The following is a description of a gene set: species: Homo sapiens Human Gene Set: TNCATNTCCYR_UNKNOWN from publication Xie X, Lu J, Kulbokas EJ, Golub TR, Mootha V, Lindblad-Toh K, Lander ES, Kellis M (PMID 15735639) Genes having at least one occurrence of the highly conserved motif M75 TNCATNTCCYR in the regions spanning 4 kb centered on their transcription starting sites. The motif does not match any known transcription factor binding site. Comprehensive identification of all functional elements encoded in the human genome is a fundamental need in biomedical research. Here, we present a comparative analysis of the human, mouse, rat and dog genomes to create a systematic catalogue of common regulatory motifs in promoters and 3' untranslated regions (3' UTRs). The promoter analysis yields 174 candidate motifs, including most previously known transcription-factor binding sites and 105 new motifs. The 3'-UTR analysis yields 106 motifs likely to be involved in post-transcriptional regulation. Nearly one-half are associated with microRNAs (miRNAs), leading to the discovery of many new miRNA genes and their likely target genes. Our results suggest that previous estimates of the number of human miRNA genes were low, and that miRNAs regulate at least 20% of human genes. The overall results provide a systematic view of gene regulation in the human, which will be refined as additional mammalian genomes become available., and this is the list of marker genes: DNASE2B, DYNC1I2, SCNM1, PRKRIP1, ERG, NR4A3, ZNFX1, WNT3, POLR1B, MADD, GSPT1, PUS3, CHMP2A, SLC35B4, DPYSL2, LINC01138, RNF220, NT5C1B, HOXA5, C19orf44, RASGRP3, CD96, INTS9, CPEB3, TLE4, CNPY2, CDIN1, HDAC8, HMBOX1, ZNF546, MRPL34, UNC80, P2RX3, SOX12, DDX47, RDH11, CAVIN2, DTX2, SHKBP1, C5orf22, HOXC12, DDX25, PRAF2, ZNF471, PAX2, COX7B, FTSJ1, SNAPC3, UBE2N, DFFA, SYMPK, ALKBH8, ENOX2, SMPD3, ZNF568, OPHN1, CD180, LYSMD1, VPS41, ZNF189, FKBPL, ZFP2, KLF12, BET1, ZNF263, GSK3A, HMG20A, AGTRAP, PNKD, CSRNP2, LRRTM3, PSMC3 (NCBI Gene Id 96121), NTAN1, BABAM1, COL6A3, PRPF19, FEM1A, SAMD12, GFUS, IPO7, ZNF569, BIN1, FOXO4, MRPL54, ZNF570 (zinc finger protein 570), ZNF571 (zinc finger protein 571), CSMD3, TMED5, CLEC7A, MICOS13, MPI, DROSHA, ZNF420, BDNF, AMTN, DEF6, PDE6D, PIK3CG (NCBI Gene Id 5294), PLPP7, FOXA3, TTC1, WWOX, LMO4, COQ10A (coenzyme Q10A), HSD17B4, TLR7 (NCBI Gene Id 51284), MTR, MEN1, INIP, COX7C, AAMP, PTPN11, LMO3, MON1A, ST3GAL2, ABCB1, FYN, PARP8, NSD3, CALR3, DRC7 (dynein regulatory complex subunit 7), CASK, PPP2R5B, CARF, MRPL50, HOXD1, MARCHF5, DCAF1, APBA3, STX16, MED15, GPR183, ADAM22, MAP2K6, SAP130, HSD11B1L, ATF6B